The following is a description of a gene set: species: Homo sapiens Neighborhood of SUPT3H Neighborhood of SUPT3H suppressor of Ty 3 homolog (S. cerevisiae) in the MORF expression compendium Human Gene Set: MORF_SUPT3H, and this is the list of marker genes: LGI1, PAX7, HSD3B2, RB1CC1, ZNF157, TBX19, ABCB10, SLC6A2 (solute carrier family 6 member 2), SOX11 (NCBI Gene Id 6664), ZSCAN26, MPZL1, NFAT5, NOL4, AKAP3, FOSL1, MEOX2, CEP162, NEB, TTN, PSG1, FSHR, TRIO, IL13RA1, ROR2, TTTY1, KPNA1, MDM2, SLC4A4, RORB, ITIH3, SIM2, SLC26A4, COL14A1, SLC46A3, ITGBL1, SLC14A2, KDR, DRC3, CYP2C19, PHLDB1 (pleckstrin homology like domain family B member 1), SOCS6, MINDY2, FZD5 (frizzled class receptor 5), BRWD1, ERC2-IT1, PTPRB, MAGI1, CD8A (CD8 subunit alpha), LINC03124, LILRA4, GUCY2F, ATP4B, EPHB2, KRT2, NPFF, GCM1, ERC1 (ELKS/RAB6-interacting/CAST family member 1), NOS2, C6, ATP8B1, RYR1 (NCBI Gene Id 906), S100A5, CXCL5, CDH8, AMMECR1, ISL1, HOXC11, SGCD, HNF1A, DNAJC16, ADAM22, FAS, TACC2, ITGA2, CALN1, RREB1, EYA1, MYT1, PAXIP1, PHOX2B (paired like homeobox 2B), MPP3, REPS2, ENTPD3, POLR1HASP, CYP2E1, CYP11A1, RUNX2, NHEJ1, CACNA2D1, CACNB1, TNIK, MLLT10, FNTB, NR3C2, PDE4D, FLRT2, FRY, DRD1, SFRP4, PDE6A, PART1, ERCC4, CLCN3, CRHR1, BCL2L11, ZBTB40, GPR19, IL16, SPATA2, JRKL, CCN6, STAG1, HTR2C, JADE3, RUFY3, KRT33A (NCBI Gene Id 3883), IL11RA, CA3, POU6F1, ANXA10, GPR171, MAP2, FBXL4, BIRC5, TNK1 (NCBI Gene Id 8711), POU6F2 (POU class 6 homeobox 2), GPR18, SLC15A1, ADAM20 (NCBI Gene Id 8748), FGF2, SMYD3, SYT5, HCRTR2, BRD4, MSL3, RAD51D, CMKLR2, BRINP3, RSC1A1, OTC, OR10H3, PCM1, CHRNB4, OPCML, ABCC8, DAZL, RXRG, ADGRL2, OR2B6, TPD52L1, DGCR5, PDPN, COX6A2, CPB2, GLRA3 (glycine receptor alpha 3), SRPK3, TANC2, DMPK, MASP2, LECT2 (leukocyte cell derived chemotaxin 2), BARX2, CFH, WBP4, MYH2, TLL1, PVR, PTPRR, HSPA1L, ATF2, RBMXL1, PTPN20, GJB5, UBE4B, SPA17, POLR2K (NCBI Gene Id 5440), LDB3, PSD, DMD (NCBI Gene Id 548327), ZNF132, HEPH, SERPINA4, IFNA8, APOBEC1, FGA, SLC33A1, OR7A5, PPP2R5B, ABCB1, NPAS2, IFNA1, LILRA1, PDCD1, TRIM24, SIX6, STAC, CDR1 (cerebellar degeneration related 1), CDC73, MON2, DNAJC22, ELAVL2, NEDD4L, B4GALT6, PAX6, CCL16, DDX52, FAM110B, SOAT2, PPM1E, SLC4A8, H3C6, ZNF33B, BMP10, PLEKHB1, KNG1, MAP3K1, F2RL1, CBLN1, KCNA5, GNG4, GPR15, FUT1, IPO9, P2RY10, MAP2K7 (mitogen-activated protein kinase kinase 7), GCA, RPS6KA5, PCDHGB7, TMEM26, AQP7, ECM2, RGS7, TBXT, CPEB3, VIP, OCM, ZBTB14, USP46, ST8SIA1, LRP4, BRCA1, PCDHB17P, C1orf216, CAMTA1, SUPT3H, TFDP2, SLC17A1, HOXB7, MSH3, IFNW1, SLC22A6, POLR3F, IL5, COLGALT2, ADAMTSL3, EDIL3, KRT34 (keratin 34), GHRHR, HTR1E, TENM4, ZNF266, ARL3, AOC4P, IFNA2, MC5R, THPO (NCBI Gene Id 84434), GYS2 (NCBI Gene Id 2998), SLC17A3, ZNF202, COQ7, IFNA14, NR1I2, PGM3 (NCBI Gene Id 5238), ATF6B, ARFGEF2, PRKCA, MAGEA8, SPRR2C, TSSK2, PKP1, R3HCC1L, SULT4A1, LORICRIN, GABRB2, PLPPR4, NOVA1, GRIK1, GUCY2C, F2RL3, TSPAN2, SCN7A, ABO (NCBI Gene Id 28), PPP1R12B, COL19A1, CCR3, IL7, IFNA10 (NCBI Gene Id 3446), ULK2, IGKV7-3, RYR3, IL4, SEMA6A, TSHB, ATP2B2 (ATPase plasma membrane Ca2+ transporting 2), CTSB, GABRA1, PHF10, STARD5, RNF24, ZNF141, CAMK4, COL8A1, GLE1, FGF18, MAGEA9 (MAGE family member A9), DBT, CDH4, NTNG2, ZNF134, VSTM4 (V-set and transmembrane domain containing 4), ATXN3, RBBP7, KLRC4, CTRL, CADM4, PLA2R1, CYP2D6, EXOC4, CDKL5